The following is a description of a gene set: Human Gene Set: GOBP_POST_TRANSLATIONAL_PROTEIN_TARGETING_TO_ENDOPLASMIC_RETICULUM_MEMBRANE studied in species Homo sapiens The targeting of proteins to a membrane that occurs after their translation. Some secretory proteins exhibit posttranslational transport into the endoplasmic reticulum (ER) lumen: they are synthesized in their entirety on free cytosolic ribosomes and then released into the cytosol, where they are bound by chaperones which keep them in an unfolded state, and subsequently are translocated across the ER membrane., and this is the list of marker genes: HSPA5, SGTB, SEC61A2, GET1, SEC63, GET4, SEC62, SEC61G, SEC61A1, CHMP4A, UBL4A, GLP1R, BAG6, SEC61B, CHMP4B, SGTA